The following is a description of a gene set: Human Gene Set: HP_ABNORMAL_CIRCULATING_SERINE_CONCENTRATION species: Homo sapiens Abnormal circulating serine concentration Any deviation from the normal concentration of serine in the blood circulation., and this is the list of marker genes: SLC7A7, PHGDH, SLC25A13, PSPH, PSAT1